Given this list of marker genes Actc1, Drp2, Sgce, Lama4, Actg2, Sgcd, Dtnb, Sgca, Acta1, Sgcb, Sspn, Dag1, Sntb2, Sntb1, Utrn, here is a description of the gene set: This event has been computationally inferred from an event that has been demonstrated in another species.<p>The inference is based on the homology mapping from PANTHER. Briefly, reactions for which all involved PhysicalEntities (in input, output and catalyst) have a mapped orthologue/paralogue (for complexes at least 75% of components must have a mapping) are inferred to the other species. Reactome Pathway: Formation of the dystrophin-glycoprotein complex (DGC) electronically inferred by orthology from the curated human pathway studied in species Mus musculus part of: Non-integrin membrane-ECM interactions